The following is a description of a gene set: Human Gene Set: HP_ABNORMAL_TOTAL_BASOPHIL_COUNT Abnormal total basophil count studied in species Homo sapiens Abnormal increase or decrease of absolute number of basophils in the blood, per microliter, compared to a reference range for a given sex and age-group., and this is the list of marker genes: SRSF2, ASXL1, KIT, BACH2, TET2